Given this list of marker genes IL21, TNFSF13, BTLA, C3, CD82, CD1D, ZEB2, AICDA, IFNG-AS1, ICOS, TLR4, CCL19, SH2D1A, PDCD1, SYK, EBI3, IL10, PTPRC, CD19, TLR7, BCL6, CD79A, IRF8, FOXO1, IFNAR2, STAT5A, CR2, CXCR5, CD22, GPR183, NEAT1, PAX5, CD80, CD69, BACH2, XBP1, IL6, BLNK, CXCL12, MS4A1, HSPA8, TMSB10, IL12A, CCL21, MAF, CXCR4, ITGB2, TNF, ITGAX, MFGE8, PTCRA, PRDM1, TBX21, IL4, FCRL5, C4A, SLAMF7, CCR7, IFITM1, CRP, SELL, ICOSLG, ETS1, IRF4, BCR, IL2, CD40, CD40LG, IFIT2, TNFSF13B, CXCL13, ISG15, IFNG, CR1, here is a description of the gene set: Extrafollicular and follicular B cell activation by SARS-CoV-2 studied in species Homo sapiens Human Gene Set: WP_EXTRAFOLLICULAR_AND_FOLLICULAR_B_CELL_ACTIVATION_BY_SARSCOV2